The following is a description of a gene set: Human Gene Set: AIZARANI_LIVER_C17_HEPATOCYTES_3 from publication Aizarani N, Saviano A, Sagar, Mailly L, Durand S, Herman JS, Pessaux P, Baumert TF, Grün D (PMID 31292543) studied in species Homo sapiens, and this is the list of marker genes: APOE, RARRES2, SERPINE1, ORM2, CPS1 (carbamoyl-phosphate synthase 1), TF, CYP2C8, ASGR1, AHSG, AFM, ABCA1, CES1, C9 (NCBI Gene Id 12279), SULT2A1, MT2A, ACSL1, TNFSF14, FGG, APOC1 (NCBI Gene Id 341), HP, APOA5, CYP2E1, CYP8B1, EPHX1, F5, AGXT, ADH1A, CLU, ADH1B, C5, CYP2B6, APOB, HRG, PLG, ITIH3, CP, CYP3A4, VTN, SERPINC1, AZGP1, LRG1, SERPINF1, CXCL1, ITIH1, PTMS, ACSM2A, IGFBP2, A1BG, SERPINA3, C1R, SERPING1, FGA, ASGR2, NNMT, AMBP, HPX, FN1, FGB (NCBI Gene Id 2244), CYP2C19, ADH4, MST1, SELENBP1, APOC3, SLC27A5, CFB, MLXIPL, IGF2, APOA2, BAAT, RBP4, MAT1A, UGT2B7, CYP2C9, SERPINF2, FGL1, CES2, APOH, KNG1, CFHR3, PLIN5, C3, F12, ANG, APOA1 (apolipoprotein A1), CYP4F3, ORM1, SERPINA1, F2, CYP2A13, TMEM176A, CYP1A2, TMEM176B, FTCD, HPN, GPT2, CFH, C1S, SERPIND1, CRP, IGFBP1, DCXR, SAA1